Given this list of marker genes Fbln5, Lgals3, Col12a1, Ltbp2, Itih2 (inter-alpha trypsin inhibitor, heavy chain 2), Col1a2, Col8a1, Ctsd, Lum, Sftpb, Agrn, S100a10 (S100 calcium binding protein A10 (calpactin)), Serpina3k, Fn1 (NCBI Gene Id 269206), Fbln2, Nid1, Col14a1, F2 (NCBI Gene Id 14061), Lama4, Mfap4, Ccbe1, Col1a1, Ogn, Hspg2, Lama1, Col3a1, Nid2, Tnc, Col18a1, Prg2, Sftpd, Col2a1, S100a11, Npnt, Col16a1, here is a description of the gene set: Mouse Gene Set: NABA_MATRISOME_PRIMARY_METASTATIC_LUNG_TUMOR from publication Gocheva V, Naba A, Bhutkar A, Guardia T, Miller KM, Li CM, Dayton TL, Sanchez-Rivera FJ, Kim-Kiselak C, Jailkhani N, Winslow MM, Del Rosario A, Hynes RO, Jacks T (PMID 28652369) In this study, we investigated the role of the extracellular matrix (ECM) in the underlying biology of lung adenocarcinoma using an autochthonous mouse model that recapitulates the complexity of cancer initiation and progression to characterize the ECM composition of normal lung, fibrotic lung, lung tumors, and metastases. We isolated normal, healthy lung tissues from wild-type (WT) mice and microdissected KrasG12D/p53-/- primary lung tumors (KP tumors) and associated metastases to the mediastinal lymph node. Quantitative mass spectrometric profiling of the ECM composition of normal lung, fibrotic lung (from bleomycin-treated mice), primary lung tumors, and lung metastases to the lymph nodes uncovered specific signatures distinguishing these tissues. This gene set lists the matrisome proteins detected in significantly different abundance in primary lung tumor as compared to normal lung. studied in species Mus musculus Matrisome proteins detected in significantly different abundance in primary lung tumor as compared to normal lung.